The following is a description of a gene set: species: Homo sapiens The immediate defensive reaction by neural vertebrate tissue to infection or injury caused by chemical or physical agents. Human Gene Set: GOBP_NEUROINFLAMMATORY_RESPONSE, and this is the list of marker genes: C1QA, POMT2, C5AR1, CD200, PTGS2, TREM2, LRRK2, IL33, CALHM2, MIR128-1, CCL3, ADORA2A, AIF1, MAPT, ADCY1 (NCBI Gene Id 449484), PLCG2, NR3C1, NUPR1, CCDC39, DAGLA, TLR9, GNAT2, JAK2, SNCA, AZU1, LYN, TLR6, IFNGR2, ZEB2, STAP1, POMGNT1, NAGLU (NCBI Gene Id 4669), ITGB1, BPGM, IL13, ITGB2, CNTF, CTSC, VPS13A, MMP8 (matrix metallopeptidase 8), PSEN1, LARGE1, TLR3, PTPRC, IL18, SYT11, CX3CR1, CST7, IGF1, CLU, TNF, SBNO1, ADCY8, MIR181C, MIR26A1, SMO, APP, LDLR, IL6 (interleukin 6), SPHK1, TAFA3, KCNJ8 (NCBI Gene Id 3764), MIR195, TLR1 (toll like receptor 1), MMP9, NR1D1, CD200R1L, VPS54, MMP3 (matrix metallopeptidase 3), IFNGR1, TTBK1, FPR2, LRP1, MIR142, CD200R1, JUN, GRN, ITGAM, CX3CL1, MIR181B1, IL4, IL1B, MIR206, IFNG, TNFRSF1B, TYROBP, AGER